The following is a description of a gene set: Human Gene Set: GOCC_SPHERICAL_HIGH_DENSITY_LIPOPROTEIN_PARTICLE A mature high-density lipoprotein (HDL) particle, converted from discoidal HDL particles following the esterification of cholesterol in the particle by phosphatidylcholine-sterol O-acyltransferase (lecithin cholesterol acyltransferase; LCAT). studied in species Homo sapiens, and this is the list of marker genes: APOM, APOA1, CLU, APOC3, HPR, APOC2, APOA2, PON1